The following is a description of a gene set: species: Homo sapiens Volvulus Human Gene Set: HP_VOLVULUS Abnormal twisting of a portion of intestine around itself or around a stalk of mesentery tissue., and this is the list of marker genes: CHRM3, EFEMP1, FOXF1, ZMYM3, BRD4, MYH11, HDAC8, EXT2, VARS1, AP1S1 (NCBI Gene Id 574017), ATRX, PACS1, DIS3L2, SMC1A, TEK, SMC3, RAD21, NIPBL, VPS51, TAF6